Given this list of marker genes HES1, WNT4, SOX8, PKD1, AQP1, LIF, SLC22A1, WNT7B, STAT1, SOX9, CALB1, WNT9B (Wnt family member 9B), OSR1, LGR4, WWTR1, WT1, ADIPOQ (NCBI Gene Id 9370, adiponectin, C1Q and collagen domain containing), PKD2, POU3F3, NPHS2, YAP1, ACAT1, HES5, UMOD, PAX8, LAMB2, SLC22A6, PAX2, here is a description of the gene set: Human Gene Set: GOBP_METANEPHRIC_EPITHELIUM_DEVELOPMENT The process whose specific outcome is the progression of an epithelium in the metanephros over time, from its formation to the mature structure. An epithelium is a tissue that covers the internal or external surfaces of an anatomical structure. species: Homo sapiens